Given this list of marker genes PPP4R3B, MBNL1, LRRC56, COL26A1, RGS7BP, SIRPA, GRINA, AMBRA1, SIGMAR1, TRMT2B, TPPP, EML3, TMEM8B, ARAP1, SBK1, SDCCAG8, ARHGEF4, RAB3IP, PADI2, ERCC5, HIVEP3, AIM2, MARK2, KLHL42, DDI2, VAMP1, FOXO3, GM2A, WASHC4, C1orf198, SLCO4A1, KRT31, ADORA3, GPR35, CAPN5, KBTBD7, ZNF383, MYO9B, PTK2, CCDC17, KCTD12, SENP6, TLR7, TCF12, WRN, SLC8B1, EPHB2, ITGB2, FZD10, RAP1A, PIK3CD, RAI2, TNFAIP3, RASA4, SLC6A6, ANKIB1, NEUROD6, HLA-E, CNN2, LDLRAD3, PTMS, ALS2, STARD3, RETREG3, VANGL2, SLC35C2, REP15, MAP7D1, FAM110D, NFKBIE, ADGRG5, TUBGCP5, SCAMP2, SPATA6L, CIITA, NIPBL, TRIT1, ZDHHC9, BCL7C (BAF chromatin remodeling complex subunit BCL7C), STOML3, ATP13A2, TBC1D10C, PRKAG2, ZNHIT2, SNX17, FAM193B, LEFTY1, UNC93B1, DOCK8, MATN2, PLEKHB2, ZNF467, RBM5, LMAN2L, ZNF18, SPIN1, ADIPOR2, HPS5, DIPK1A, HAAO, ARHGAP45, RGP1, NECAP2, SLC66A1, CUL9, FBXL17, MAP4K3, SYK (NCBI Gene Id 6850), BCL2L2, RAI1, C2CD5, PLEKHA2, RTL5, TRAPPC10, ORC4, PTPRC, HSD11B2, WNK1, BASP1, SEPSECS, BORCS6 (BLOC-1 related complex subunit 6), PTPN20, SLAMF9, ATP6V0B, SASH3, THY1, BSCL2, MYOG, ZMIZ2, STX16, CLCN4, FAM76B, TRAPPC5, ZNF217, SERPINA4, P2RY12, FAM171B, RAC2, DNAJC4, NR3C1, SIGLEC10, IL2RA, TRIM14, PLPP6, SLX4IP, CNOT8, ZC3H11A, NBR1, SCAP, LYST, RLF, BSDC1, ZNF608, WDR13, INPP5K, SIKE1, FAM120C, STRIP1, RCOR3, GIT2, ZSWIM8, ERO1B, ST8SIA6, OSTM1, RNF122, ZNF280D, TNFAIP8, UBL3, CYB5R3, TMEM258 (NCBI Gene Id 746), TMEM231, P2RY13, CRISP1, EME2, GALK1, CADPS, TMEM86A, ERBIN, CHMP1A, LGALS4, NFRKB, MAN2A1, LRRC1, DYNC1H1, USP49, ZXDB, LMF1, LRP10, MRGPRG, NR2C2AP, NDST2, ABCB4, GOLGA1, PPCS (phosphopantothenoylcysteine synthetase), RECQL5, PCMTD2, SIRT7, TMEM181, SLC12A3, TRIM44, here is a description of the gene set: Conditional macrophage-specific PPARg knockout mice were generated on C57Bl/6 background by breeding PPARg fl/- (one allele is floxed, the other is null) and lysozyme Cre transgenic mice. PPARg and IL-4 signaling was analyzed on bone marrow-derived macrophages. Bone marrow of 3 mice per group was isolated and differentiated to macrophages with M-CSF (20 ng/ml). 20 ng/ml IL-4 was used to induce alternative macrophage activation and 1 uM Rosiglitazone (RSG) was used to activate PPARg. From each mouse 4 samples were generated: 1. M-CSF, 2. M-CSF+RSG, 3. IL-4 and 4. IL-4+RSG. All compounds were added throughout the whole differentiation process, and fresh media was added every other day. Control cells were treated with vehicle (DMSO:ethanol). After 10 days, RNA was isolated and gene expression profiles were analyzed using Mouse Genome 430 2.0 microarrays from Affymetrix. species: Homo sapiens Human Gene Set: GSE25123_ROSIGLITAZONE_VS_IL4_AND_ROSIGLITAZONE_STIM_PPARG_KO_MACROPHAGE_DAY10_DN from publication Szanto A, Balint BL, Nagy ZS, Barta E, Dezso B, Pap A, Szeles L, Poliska S, Oros M, Evans RM, Barak Y, Schwabe J, Nagy L (PMID 21093321) Genes down-regulated in bone marrow-derived macrophages with PPARG knockout treated with rosiglitazone: control versus IL4.